Given this list of marker genes NFIX, RNU4-2 (NCBI Gene Id 26836), LAMA5, GPC4, LRP2, FRA10AC1, NOG, NIPBL, ARID1B, RBM10, BUB1B, SETBP1, PCGF2, GPC3, here is a description of the gene set: Short sternum Decreased inferosuperior length of the sternum. studied in species Homo sapiens Human Gene Set: HP_SHORT_STERNUM